Given this list of marker genes Frzb, Fam120b, Dop1a, Nxn, Spag8, Nova1, Cytip, Dixdc1, Tab3, B4gat1, Unc119b, Plat (plasminogen activator, tissue), Vdac1, Gabarapl1, Taf5, Iqsec3, Zfp326, Gdap2, Agbl3, Tmem255a, Nudt4, Snx7, Samd4b, Aff4, Lmcd1, Tsen15, Dpp4, Klf12, Bora, Map3k2, Slc49a4, Fbrs, Casp14, Map3k20, Dennd11 (DENN domain containing 11), Shisa9, Ano4, Elovl7, Slit2, Mrtfa, here is a description of the gene set: studied in species Mus musculus Mouse Gene Set: MIR_1927 Genes predicted to be targets of miRBase v22 microRNA mmu_miR_1927 in miRDB v6.0 with MirTarget v4 prediction scores > 80 (high confidence targets). from publication Chen Y, Wang X (PMID 31504780)